The following is a description of a gene set: studied in species Homo sapiens Abnormal circulating alpha-fetoprotein concentration Concentration of alpha-fetoprotein in the blood circulation outside normal limits. Human Gene Set: HP_ABNORMAL_CIRCULATING_ALPHA_FETOPROTEIN_CONCENTRATION, and this is the list of marker genes: AFP, PKD2, FGFR3, ATM, RNF168, PIGN, PIK3R5, NR1H4, MKS1, STK11, CTNNB1, SLC25A13, FAH, FOCAD, MAD2L2, DGUOK, NGLY1, KIT, ZBTB20, PNKP, OCRL, FLI1, MET, NPHS1, KIF12, MPV17, SETX, PRPS1, EARS2, THPO, BCL10, PKHD1, PEX6